Given this list of marker genes TEK, RPS19, CYP1B1, LTBP2, LMX1B, ADAMTSL1, here is a description of the gene set: Primary congenital glaucoma species: Homo sapiens Human Gene Set: HP_PRIMARY_CONGENITAL_GLAUCOMA